The following is a description of a gene set: studied in species Mus musculus Mouse Gene Set: REACTOME_SODIUM_COUPLED_SULPHATE_DI_AND_TRI_CARBOXYLATE_TRANSPORTERS Sodium-coupled sulphate, di- and tri-carboxylate transporters, and this is the list of marker genes: Slc13a1, Slc13a2, Slc13a4 (solute carrier family 13 (sodium/sulfate symporters), member 4), Slc13a5, Slc13a3